Given this list of marker genes Ace2, Cpa3, Enpep, Ren1, Mme, Ctsg, Ctsd, Atp6ap2, Cpb2, Ctsz, Agt, Ace, Cma1, Cpb1, Ces1d, here is a description of the gene set: Metabolism of Angiotensinogen to Angiotensins Mouse Gene Set: REACTOME_METABOLISM_OF_ANGIOTENSINOGEN_TO_ANGIOTENSINS studied in species Mus musculus